The following is a description of a gene set: studied in species Mus musculus Mouse Gene Set: GOCC_TERMINAL_BOUTON Terminal inflated portion of the axon, containing the specialized apparatus necessary to release neurotransmitters. The axon terminus is considered to be the whole region of thickening and the terminal bouton is a specialized region of it., and this is the list of marker genes: Cckar, Ntsr1, Grm7, Rab3a, Gria2, Ophn1, Syp, Snca, Ghrh, Slc18a3, Slc18a1, Prss12, Unc13b, Ap1s1, Cyfip1, Cplx3, Gabrb3, Kcnma1, Grik3, Lrrk2 (leucine-rich repeat kinase 2), Mylk2, Blvrb, Grik4, Cnga1, Erc2, Tnn, Grik2, Calca, Rapgef3, Pnmt, L1cam, Cplx1, Septin5, Ap3d1, Unc13a, Calb2, Calb1, Opn1sw, Pclo (NCBI Gene Id 26875), Grin2b, Ilk, Kcnc2, Mical1, Th, P2rx4, Cplx4, Fmr1, Cad, Grin2a, Rab5a, Adora1, Drd4, Hspa8, Cyp19a1, Sncb, Grik1, Adcyap1, Slc18a2, Prph, Scgn (secretagogin, EF-hand calcium binding protein), P2rx7, Prnp, Unc13c, Ppp2ca, Grin1, Dbh, Syt11, Grm4, P2rx2, Ntrk2, Nmu (NCBI Gene Id 56183), Cplx2, Cck, Slc1a7 (NCBI Gene Id 242607), Rpl26, Aak1, P2rx3, Slc4a8, Esr1, Gria4, Gria3, Polg, Synj1, Hcn4, Prkn, Tbc1d24, Npy, Bdnf, Ptprn2, Grik5, Oxt, Grip1, Cngb1, Dpysl2, Ush2a